The following is a description of a gene set: High-throughput gene expression profiling has become an important tool for investigating transcriptional activity in a variety of biological samples. To date, the vast majority of these experiments have focused on specific biological processes and perturbations. Here, we have generated and analyzed gene expression from a set of samples spanning a broad range of biological conditions. Specifically, we profiled gene expression from 91 human and mouse samples across a diverse array of tissues, organs, and cell lines. Because these samples predominantly come from the normal physiological state in the human and mouse, this dataset represents a preliminary, but substantial, description of the normal mammalian transcriptome. We have used this dataset to illustrate methods of mining these data, and to reveal insights into molecular and physiological gene function, mechanisms of transcriptional regulation, disease etiology, and comparative genomics. Finally, to allow the scientific community to use this resource, we have built a free and publicly accessible website (http://expression.gnf.org) that integrates data visualization and curation of current gene annotations. Human Gene Set: SU_THYMUS from publication Su AI, Cooke MP, Ching KA, Hakak Y, Walker JR, Wiltshire T, Orth AP, Vega RG, Sapinoso LM, Moqrich A, Patapoutian A, Hampton GM, Schultz PG, Hogenesch JB (PMID 11904358) species: Homo sapiens Genes up-regulated specifically in human thymus., and this is the list of marker genes: CYTIP, SLAMF1, TRAF3IP3, MMP12, RHOH, PIK3CD, PAX1, ETS1, CD1B, ITK, IRF8, HERC2P3 (HERC2 pseudogene 3), NCK2, ADAMDEC1, MYB, STK17A, SH2D1A, CD1E, IRF4, CCR9, GNA13